The following is a description of a gene set: Any process that activates or increases the frequency, rate or extent of cell cycle checkpoint. species: Homo sapiens Human Gene Set: GOBP_POSITIVE_REGULATION_OF_CELL_CYCLE_CHECKPOINT, and this is the list of marker genes: DYNC1LI1, KNL1, TTI1, TPR, TELO2, XRCC3, MAP3K20, CDCA8, TTI2, GEN1, AURKB, MAD1L1, CCAR2, BIRC5, MAD2L1, INCENP, NDC80, PROX1